Given this list of marker genes Daglb, Dagla, here is a description of the gene set: This event has been computationally inferred from an event that has been demonstrated in another species.<p>The inference is based on the homology mapping from PANTHER. Briefly, reactions for which all involved PhysicalEntities (in input, output and catalyst) have a mapped orthologue/paralogue (for complexes at least 75% of components must have a mapping) are inferred to the other species. species: Mus musculus electronically inferred by orthology from the curated human pathway Reactome Pathway: Arachidonate production from DAG part of: Effects of PIP2 hydrolysis